Given this list of marker genes ZIM2-AS1, MFSD9, CALCRL-AS1, ZNF561-AS1, PNPLA4, DCUN1D5 (NCBI Gene Id 84259), LRIF1, MIR7-3, ZNF695, ZNF555 (zinc finger protein 555), ZNF227, LRRC28, ZNF805, ZNF285, NXT2, ZNF138, ZNF626, LYPD9P, ZNF268, TTC23, MSANTD4, LINC00680, ZNF551, MIR4530, IFTAP, ZNF304, LINC00992, ZNF274, ALKBH3, YJU2 (YJU2 splicing factor homolog), TPRKB, ZNF561, ZNF728, GALNT8, ZNF35, GPATCH2, ZNF875, AURKC, EIF3F, LMTK3, LINC00665, LINC01756, HDDC2, FMO4, COX16, ZNF528-AS1, SERPINE2, GUSBP1, PAIP2B, LRRC4C, RIMBP2, PMS2CL, MAGEB2, FRMD1, LINC01164, RAB39A, SERPINB5, GFI1B, MIR7-3HG, OTOA, ZNF493, OCA2, DCTN3, TRIM24, LINC01535, CDKL3, LZTFL1, ZNF530, ZNF738, ZNF528, ALG10B, ARL14EP, PSCA, ZNF226, RPF1, CLIC4P2, SLC35F2, PXMP4, NPPB, DCAF4L2, ZNF721, COL20A1, ZNF578, FAM218A, IMPACT, RIMBP3, PIK3C3, GP6-AS1, ZNF671, VANGL1, JRK, ZNF586, CCZ1P1, PIGG, LAS1L (NCBI Gene Id 81887), SPATA17, ZNF502, SNRPB2, here is a description of the gene set: Human Gene Set: TRIP13_TARGET_GENES species: Homo sapiens from publication Yevshin I, Sharipov R, Kolmykov S, Kondrakhin Y, Kolpakov F (PMID 30445619) Genes containing one or more binding sites for (TRIP13) in their promoter regions (TSS -1000,+100 bp) as identified by GTRD version 20.06 ChIP-seq harmonization.